Given this list of marker genes CAPN2, MTOR, PKN2, PDPK1, PRKACB, PTK2, GNAS, PRKACG, PRKACA, MIR92A1, AKT1, ABL1, PTPN1, PPP2CA, SOCS5, here is a description of the gene set: Any response to fluid shear stress in a vascular endothelial cell. Human Gene Set: GOBP_VASCULAR_ENDOTHELIAL_CELL_RESPONSE_TO_FLUID_SHEAR_STRESS species: Homo sapiens